Given this list of marker genes DDC, CASP4, IFNGR1, QPCT, MCOLN1, PTGR3, CTSS, MAN1A1, KLF9, PITPNC1, ANXA4, RWDD3, ERBB3, SSTR2, DHX58, PRKCE, LTBP3, ARC, SOWAHA, DECR2, LY6D, FNDC10, RAB11FIP5, DIO2, TIFA, B3GNT5, HLA-C, ABCA1, IGF2R, KMO, RAB38, DBP, VEGFC, RASL11B, EMP1, PKP3, TANC1, CD99L2, RELL1 (NCBI Gene Id 768211), RGS8, MBOAT1, CYSLTR2, PTPRA, ALCAM, CALCRL, FEZ2, CPQ, CTSW, ENDOU, NCOA1, WLS, DNTT, HMGN3 (high mobility group nucleosomal binding domain 3), GBP6, KANSL1L, INSL6, BCL6, TRAF3IP2, INPP5K, CAMK1D, ATP1B1, UNC119B, TCF7L2, GTPBP2, DNASE1L1, RTP4, OSBPL1A, UCHL1, ABTB1, PTPN22, SCML4, APCDD1, MYL10, TPRG1L, ITPR2, SLC30A4, MPP1, KRT85, SERPINE2, GPRC5B, IRF1, SLC14A1, CCDC28A, MUC13, TMEM71, MEF2C, MXI1, KIF17, RAB6B, SERPINI1, SUN2, TNFRSF18, TEP1, SYNJ2, SMC1B, LANCL1 (LanC like glutathione S-transferase 1), PARN, ZBTB20, GOSR1, P2RY14, RBM43, FGF13, ANAPC5, DDHD2, STAG3, ISOC1, ADGRD1, PARD3B, CD84, PIPOX, SMOX, LAMB3, TMEM63A, FRMD6, PCK2, RCAN3, TSC22D3, CDKN2C, IGHM, IL27RA, GSTM5, SYTL2, SNX9, BBS9, B2M, ST6GAL1, YPEL3, ARHGAP29, GBP4, SYNE1, OAS1, SCARB2, FOXJ2, AGTRAP, LGALS8, SARAF, CCNG2, PTGER2, IL6ST, SLCO3A1, ANXA9, TP53INP1, TBC1D24, ACADL, CSGALNACT1, CYP4V2, ATP6V1D, BCL2L2, ADCY6, LATS2, RPS6KA2, SLC66A3, STK11, MS4A6A, DGLUCY, BLNK, CD96, CASP1, BAIAP3, EPB41L4B, PCBP3, MXD3, MDFIC, IFIT2, BLK, JPT1, TOB2, LAPTM4B, MKRN1, RSAD2, CD247, PLD3, DHRS3, CCR9, YPEL5, GPSM2, SELL, PISD (phosphatidylserine decarboxylase), WBP1, DMC1, ENC1 (NCBI Gene Id 8507), KLF6, NEFH, ATP6V0A2, FBXO28 (NCBI Gene Id 23219), GRN, TMEM176B, DSTYK, CD6, SYTL4, ID3, HLA-B, PHLPP1, ARHGEF18, TMEM191C, SLC37A2, STAMBPL1, PLXDC1, HOXA9, NANOG, here is a description of the gene set: Genes up-regulated in comparison of adult DN2 thymocytes versus fetal DN2 thymocytes. studied in species Homo sapiens Human Gene Set: GSE24142_ADULT_VS_FETAL_DN2_THYMOCYTE_UP from publication Belyaev NN, Biró J, Athanasakis D, Fernandez-Reyes D, Potocnik AJ (PMID 22581009) Development of T-cells provides a unique opportunity to study cell-fate determination due to the accessability and the well defined stages of developmental stages. In order to understand the genetic programs underlying fetal and adult T‑cell fate specification we subjected highly purified fetal and adult T-cell progenitor populations to a genome‑wide transcriptional analysis. The aim was to identify molecular elements that govern T-cell fate specification as a whole but ultimately to isolate elements that were specific for a given population in a specific developmental window.